The following is a description of a gene set: Genes down-regulated in comparison of control dendritic cells (DC) at 0 h versus those stimulated with LPS (TLR4 agonist) at 0.5 h. Human Gene Set: GSE17721_CTRL_VS_LPS_0.5H_BMDC_DN studied in species Homo sapiens from publication Amit I, Garber M, Chevrier N, Leite AP, Donner Y, Eisenhaure T, Guttman M, Grenier JK, Li W, Zuk O, Schubert LA, Birditt B, Shay T, Goren A, Zhang X, Smith Z, Deering R, McDonald RC, Cabili M, Bernstein BE, Rinn JL, Meissner A, Root DE, Hacohen N, Regev A (PMID 19729616) mouse primary BMDCs were stimulated with tlr ligands and gene expression changes were profiled on Affymetrix arrays, and this is the list of marker genes: SLC25A20, MLLT3, SYNGR2, STK32B, TSNAXIP1, VPS18, TLL1, METRNL (meteorin like, glial cell differentiation regulator), MOS, SIX4, SATB2, NDUFB7, UNC119B, NOP2, SMAD1, THAP7, MRPL12, PARVB, RBMX2, RPLP2, SMR3A, NUCB2, MARCKSL1, SRRT, SOX5, UROS, RPL39, ZNF821, SNRNP70, TSPY1, OSBPL6, SLC16A2, RPLP0, PTPRE, SEZ6L, LRRC42, ZC3H12C, TECTB, LY96, UBL5 (ubiquitin like 5), PDPK1, SMYD5, PTPN2, MARK4, TIMP1, EIPR1, VTI1A, SHBG, SFTPC, MPV17, TMED3, SYNE1, PRKCQ, SH3YL1, SCGN, NFATC1, SCN4A, MUTYH, CIMAP1A, TXNDC9 (NCBI Gene Id 10190), RBM26, TC2N, ASAH2, WDR54, ZSCAN21, OLFML3, SUN1, MRPL1, PTPRM, NDUFB2 (NCBI Gene Id 4708), NUDT9 (NCBI Gene Id 79013), RPF2, TP53RK, SHARPIN, MYCT1, TBX19, TJP2, ZFP36, MAP3K8, PDZRN3, MMP23B, RAG1, NRARP, MGAT4C, SPIRE2, PCTP, MYOZ2, RPS6KB1, MOGAT2, SMAGP, TWIST2, NEUROG3, SLC4A1 (solute carrier family 4 member 1 (Diego blood group)), SLC17A3, MTHFS, PLEKHB1, TBCC (NCBI Gene Id 6903), LY6H, RFXANK, SLC25A53, NUDT7, MID2, MRTFB, SIGIRR, TNFSF13B, ZFP1, ZNF276, POLR2K, MMP17, MYL9, TSPAN33, STRADA, MBD6, SIAH1, TTN, NKAPL, PI4K2A, ONECUT3, PPP2R3A, MXD4, MTAP (methylthioadenosine phosphorylase), TKTL1, PURB, RCC1, TFAP2B, MAN2B2, RBP2, LTC4S, MBP (myelin basic protein), NHERF2, PLEKHO1, POLR2F, ZC3H12A, MRM1, TLL2, PLAGL1, R3HCC1, TMEM115, MYB, WDR83OS, TNFRSF14 (TNF receptor superfamily member 14), TRMT1, TCTE1, LRP1B (NCBI Gene Id 55424), SLC27A1, PLPBP, TBX6, VASN, PRRC1 (NCBI Gene Id 133619), TMPRSS11D, LRRC59, REEP6, SPOCK2, NPPC, PTPRG, RDH16, SYTL2, TPI1, NSMF, TRPS1, SCN11A, NDUFB11, TBC1D20, TRMT10B, SART1, MYO6, RIN1, LTBP2, TTK, NELL2, PSMG4, WFDC1, MMP1, OR5P3, OSR2, TNIP2, OTP, PHLDA1, TMEM39A, SCML4, TRAP1, RAD51B, PSMD4, TTLL1, MAP2K3, SH3D19, TMEM50B, PLA2G6, S100G, MOGS, RGS4, SPRY2, TNS2, ZYX, NUP37, SLC9B2, SRPK1, PHKG2, MAP4K2, PPM1D